The following is a description of a gene set: studied in species Mus musculus Binding to a macrolide, any of a large group of structurally related antibiotics produced by Streptomyces species. Mouse Gene Set: GOMF_MACROLIDE_BINDING, and this is the list of marker genes: Fkbp1b, Ppid, Alb, Lcn2, Fkbp10, Fkbp1a